The following is a description of a gene set: Reduced level of nasal nitric oxide (nNO). Current American Thoracic Society/European Respiratory Society (ATS/ERS) guidelines for nNO measurements recommend air aspiration via a nasal probe while the subject exhales through the mouth against resistance in order to maintain velum closure. species: Homo sapiens Decreased nasal nitric oxide Human Gene Set: HP_DECREASED_NASAL_NITRIC_OXIDE, and this is the list of marker genes: SPAG1, DNAH5, DNAH11, CFAP298, CFAP45, DNAI2, CFAP300, LRRC56, ZMYND10, BRWD1, DNAAF5 (dynein axonemal assembly factor 5), MCIDAS, DNAJB13, CFAP74, DNAAF6, RSPH4A, NEK10, WDR19, CCDC65, DRC1, RSPH9, CCNO, DNAH9, RSPH3, RSPH1, ODAD4, ODAD3, CFAP52, ARL2BP